Given this list of marker genes APOC1, ASXL3, CYP7A1 (NCBI Gene Id 1581), KLHL25, ACADVL, PDGFB, PROX1, SNAI1, GGCX, UBR4, PDE8B, ERLIN2, FGF19, ERLIN1, FBXW7, SNAI2 (snail family transcriptional repressor 2), MIR206, NFKB1, MIR33A, C7orf50, PIBF1, PRMT3, MIR342, MIR185, TRIB3, GFI1, REST, SIK1, PDGFA, SCAP, ORMDL3, DCAF5, MIR98, LPCAT1, MIR9-1 (NCBI Gene Id 407046), WDTC1, SIRT1 (NCBI Gene Id 23411), ABCA2, CEACAM1, ACADL, DKKL1, SERPINA12, BMP2, BMP5, INSIG2, DKK3, MIR132, MIR1-1, CCDC3, ORMDL1, LPIN1, MIR766, NR0B1, MIR204, MALRD1, ORMDL2, ANGPTL4, INSIG1, ATP1A1, TMX1, MIR548P, PRKAA1, GPER1, APOC3, SPHK1, MIR30C1, WNT4, AKR1C3, APOE, BRCA1, here is a description of the gene set: Any process that stops, prevents, or reduces the frequency, rate or extent of the chemical reactions and pathways resulting in the formation of lipids. Human Gene Set: GOBP_NEGATIVE_REGULATION_OF_LIPID_BIOSYNTHETIC_PROCESS species: Homo sapiens